The following is a description of a gene set: studied in species Homo sapiens Top marker genes in medulloblastoma associated with poor response to treatment (poor outcome). Embryonal tumours of the central nervous system (CNS) represent a heterogeneous group of tumours about which little is known biologically, and whose diagnosis, on the basis of morphologic appearance alone, is controversial. Medulloblastomas, for example, are the most common malignant brain tumour of childhood, but their pathogenesis is unknown, their relationship to other embryonal CNS tumours is debated, and patients' response to therapy is difficult to predict. We approached these problems by developing a classification system based on DNA microarray gene expression data derived from 99 patient samples. Here we demonstrate that medulloblastomas are molecularly distinct from other brain tumours including primitive neuroectodermal tumours (PNETs), atypical teratoid/rhabdoid tumours (AT/RTs) and malignant gliomas. Previously unrecognized evidence supporting the derivation of medulloblastomas from cerebellar granule cells through activation of the Sonic Hedgehog (SHH) pathway was also revealed. We show further that the clinical outcome of children with medulloblastomas is highly predictable on the basis of the gene expression profiles of their tumours at diagnosis. from publication Pomeroy SL, Tamayo P, Gaasenbeek M, Sturla LM, Angelo M, McLaughlin ME, Kim JY, Goumnerova LC, Black PM, Lau C, Allen JC, Zagzag D, Olson JM, Curran T, Wetmore C, Biegel JA, Poggio T, Mukherjee S, Rifkin R, Califano A, Stolovitzky G, Louis DN, Mesirov JP, Lander ES, Golub TR (PMID 11807556) Human Gene Set: POMEROY_MEDULLOBLASTOMA_PROGNOSIS_DN, and this is the list of marker genes: RPL27A, RPS18 (ribosomal protein S18), SRI, IARS1, RPS25, BARD1, RPL35A, TRAP1, ERP29, RPL7A, RPL29, TKT, SNRPD2, CBX5, UCHL1, NCAPD2, NME4, E2F5, GABRG2, RPS19, FGFR3, RPL10A (NCBI Gene Id 4736), COX8A, CGB3, B4GALT1, HMGA1 (high mobility group AT-hook 1), RPS14, MYBL2, UBE2D3, CDC25B, RPS10, SLC29A1, RPSA, ENO1, CAD, SNRPA1, DAG1, RPS8, ATIC, RPL11, CENPF (NCBI Gene Id 51468), BYSL, LDHB, ATP5MC2